Given this list of marker genes Mtf1, Tspan12, Ikzf4, Klhl24, Abhd6, Ppp2r5c, Anpep, Gal3st2, Ppm1h, Abtb1, Scn2b, Scara5, Kmt5c, Pafah1b1, Usp38, Crem, Sel1l, Osgep, Ptpn1, Cyyr1, Rfx3, Zswim6 (zinc finger SWIM-type containing 6), Zfp518a, Nrm, Mfsd9, Orc2, Mamdc2, Vps4b (vacuolar protein sorting 4B), Lactb, Lhx8 (LIM homeobox protein 8), Ajuba, Retreg2 (reticulophagy regulator family member 2), P2rx4, Ppat, Zfyve1, Mcl1, Kcnk10, Nup210, Man1b1, Abcc5, Lin28a, Tada3, Plxna1, Zfp704, M6pr, Ahrr, Nhsl3, Tmem72, Grsf1, Tle3, Ube2g1, Arid3a, Msrb3 (NCBI Gene Id 320183), Bmf, Vps37b, Enpep, Acads, Syvn1, Eif1ad, Trp53inp1, Mobp, Ist1, Kcna1, Pcsk7, Myt1, Bet1, Cyth1, Ttc7, Dram2, Ino80d, Stard13, Zbtb34, Ankrd50, Atxn1, Brip1, Nfkbib, Gpatch8, D17H6S53E, Trim71, Tnfsf4, Trem6l, Ulk3, Dhx33, Rufy3, Cgref1, Tnfaip3, Gtpbp2, Shtn1, Ovol1, Ninl, Golga5, Il16 (interleukin 16), Podxl, Nim1k (NIM1 serine/threonine protein kinase), Tor2a, Zdhhc9, Lrrc10b, Lfng, Eif4ebp1, Itga8, Nkapd1, Borcs6, AU040320, Tbc1d8b, Nin, Tmtc2, Ptpn7, Nipal4, Xirp1, Rfxank, Rap1a, Eaf1, Ceacam1, 2610528J11Rik (RIKEN cDNA 2610528J11 gene), Plekhm3, Jade2, Frmd5, Npl, Cnnm1, Dvl1, Tjap1, Khnyn, Ncan, Dtx4, Dennd6a, Eva1a, Il6ra, Zfp62, Rasgef1a, Slc35a4, Zfp488, Tmprss13, Rbak, Hic2, Fut1, Grb10, Tmem120b, Cdc42se1, Dnajc14, Sertad3 (SERTA domain containing 3), Zbtb7a, Smurf1, Speg, Prss33, Suv39h1, Zscan29, Fam83h, Ccnj, Retreg3, Cntd1, Sema4d, Scgb1b30, Tmem161b, Bhlhe41, Bak1, Ppp2ca, Alg6, Prdm1, Hdac3, Mfsd13a, Ier2 (NCBI Gene Id 15936), Cdk19, Sgpl1, Bnip2, Fbxw4, Atp11a, Mapre2, Sptb, Phactr3, Tent5a, Rbm7, Blzf1, Cyp24a1 (NCBI Gene Id 13081), Kctd21, Galnt5, Slc39a9, Lin28b, Cgn, Hapln1, Tgoln1, Tafazzin, Nr6a1, Glb1l2, Cdh5, Cdk16, Cdc37l1, Sbno1, Dynlt3, Daam1, Sarm1, Elovl6, Vdr (vitamin D (1,25-dihydroxyvitamin D3) receptor), Kcns3, Serpinb9d, Fam234b, Dock3, Ercc6l2, Abcb11, Acer2, Lclat1, Cdr2l, Tmem132e, Slc25a35, Cln6, Mfhas1, Cbx7, Rhoq, Sema4c, Ubr7, Ttc29, Galnt14, Prdm2, Klc2, Sstr3, Zfp408, Dicer1, Neu1, Ebf4, Mlf2, Nbeal2, Samd10, Gga2, Diras1, Klf13, Slc25a15, Cacna1b, Pcgf6 (polycomb group ring finger 6), Sec14l2, Hif1an (NCBI Gene Id 77039), Scarb1, Sh3bp5l, Tbc1d1, Bag4, Tril, Abhd3, Necab3, E2f2, Zfp523, Ier3ip1, Rora, Zswim5, Kbtbd13, Alpk3, Gpr153, Prtg, Atg4d, Was, Slitrk6, Slc6a17, Map3k11, Gcnt1, Lif, Ppp4r3a (protein phosphatase 4 regulatory subunit 3A), Tmem25, Rbm20, Bap1 (NCBI Gene Id 69465), Pi4k2b, Osbpl9, Chtf8, Dus1l, Kcnip3, Sh3tc2, Ctnnal1, Arid3b, Sema4b, Gal3st2c, Crb2, Casp2, Irf4, Fam118a, Cdc42bpg, Scn4a, Zbtb37, Grk4, Stat3, Grhl1, Nckap5l, Triap1 (TP53 regulated inhibitor of apoptosis 1), Lrp4, Ndufs4, here is a description of the gene set: from publication Chen Y, Wang X (PMID 31504780) Mouse Gene Set: MIR_351_5P Genes predicted to be targets of miRBase v22 microRNA mmu_miR_351_5p in miRDB v6.0 with MirTarget v4 prediction scores > 80 (high confidence targets). species: Mus musculus